The following is a description of a gene set: studied in species Homo sapiens Human Gene Set: HP_IRIS_COLOBOMA Iris coloboma A coloboma of the iris., and this is the list of marker genes: NOTCH3, POLR1D, CRIPTO, MPDZ, MAF, LARGE1, YAP1, GLI2, TCEAL1, ALG2, NRAS, POMT1, FGF3, TCTN1, HRAS, CRYGD, NSUN2, WNT3, CBY1, ROR1, CTBP1, RBP4 (retinol binding protein 4), B3GALNT2 (beta-1,3-N-acetylgalactosaminyltransferase 2), TCTN2, CRYGC, SPTBN1, FGFR2, B4GAT1, PIBF1, SMO, VSX2, LIG4, COL4A1, CCDC22, RAP1B, KATNIP, POMK (NCBI Gene Id 84197), ARL3, MMP2, ANK1, TBX22, CRYBB2, TFAP2A, GJA8, ARL13B, IFT74, POLR1B, WASHC5, SHH, DLL1, DAG1, CEP290 (centrosomal protein 290), GAS1, SRD5A3 (steroid 5 alpha-reductase 3), TRIM37, TGIF1, TOGARAM1, RERE, SUFU, DPYSL5, CSPP1, CC2D2A, KIFBP, PNPLA6, PTCH1 (NCBI Gene Id 8015), AHI1, NPHP1, FGFRL1, SIX3, TMEM231, BMP4, SALL2, MKS1, SALL1, HCCS, SEMA3E, SIN3A, NELFA, MED12L, MIR204, NOTCH2 (notch receptor 2, NCBI Gene Id 55574), PDE6D, POGZ, HMGB3, ADNP, TMEM216, INPP5E, FKTN, ZIC2, CDON, IGBP1, PXDN, CPLANE1, ATOH7, RXYLT1, CPLX1, ATP6V1A, LRP2 (NCBI Gene Id 4036), ACTG1 (actin gamma 1), ZEB2, KMT2D, B3GLCT, MAFB, FLI1, CEP120, FOXH1, CRYBB1, TMEM218, OFD1, PUF60, KIAA0586, PRR12, FKRP, HYLS1 (HYLS1 centriolar and ciliogenesis associated), SIX6, VPS35L, KIAA0753, ALG3, NODAL, TBX4, POMT2, ESAM, POLR1C, FZD5, HMX1, NDUFB11, CRYAA, TCOF1, CEP41, MMP14, PORCN, FGFR1, FLNA, ABCB6, TMEM237, COX7B, RB1, C12orf57, NSD2, SOX2, GDF3, MBTPS2, POMGNT1, TENM3, RSPO2, ZNF423, CHD7, BCOR, ACTB, RPGRIP1L, B9D1, CRPPA, PTCH2, GZF1, CRYBA4, ALX3, KRAS, TMEM67, KCTD1, CENPF, ERF, DACT1 (NCBI Gene Id 51339), CEP104, DHCR7, B9D2, CHN1, ELP4, PIGG, TCTN3, POMGNT2, SALL4, DISP1 (NCBI Gene Id 84976), GNAQ, DYRK1A, VPS13B, LETM1, FGF8 (fibroblast growth factor 8), TMEM138, NAA10, ARMC9, SMCHD1